Given this list of marker genes Ndp, Sulf1, Afg3l2, Chrnb2, Slc24a4, Hoxb3, Ackr3 (NCBI Gene Id 98703), Chd7, Egr2, Ext1, Gabrb2, Atoh7, Scn8a, Lrig1 (leucine-rich repeats and immunoglobulin-like domains 1), Dmd, Tifab, Npr2, Hoxb1, Vcam1, Kcna1, Kcnc1, Tfap2a, Nkx2-2, Ark2c, Ednra, Plxna1, Kcnq3, Ilk, Atp8b1, Phox2a, Kcnc2, Hoxd3, Cited2, Nrtn, Edn1, Six4, Pou4f3, Scn1a, Large1, Lrit3 (leucine-rich repeat, immunoglobulin-like and transmembrane domains 3), Slc38a8, Ret, Fbxo45, Hoxa1, Tmem126a, Nrp2, B4galnt1, Ntf5, Slitrk6 (SLIT and NTRK-like family, member 6), Hes3, Bdnf, Tbx1, Ctnnb1, Epha4, Nrp1, Ctsl, Ngfr, Pou4f1, Ephb2, Mnx1, Sulf2, Unc13b, Isl1, Ntrk1, Lrig2, Tcirg1, Drgx, Ephb1, Serpine2, Prkcg, Adarb1, Slc25a46, Itga4, Mafb, Dag1, Ntf3, Kcnq2, Six1, Col25a1, Ngf, Kcna3, Erbb3 (erb-b2 receptor tyrosine kinase 3), Dicer1, Nav2, Scn2a, Lpar1, Hes1, Sema3a, Nptx1, Unc13a, Naglu, Gabrb3, Hoxa3, Phox2b, Ece1, Pax2, Fgfr3, Plxna3, Gabra5, Neurog1, Hoxb2, Plxna4, Sema3f, Slc1a3, Gli3, Sall1, Kcna2, Rpl24, here is a description of the gene set: species: Mus musculus The process whose specific outcome is the progression of a nerve over time, from its formation to the mature structure. Mouse Gene Set: GOBP_NERVE_DEVELOPMENT